Given this list of marker genes UBA1, MYSM1, SLC19A1, SLC30A7, DDX41, here is a description of the gene set: Dysplasia in the erythroid lineage, which presents with a variety of morphological changes in the bone marrow, including nuclear budding or irregular nuclear contour in erythroblasts. Erythroid dysplasia Human Gene Set: HP_ERYTHROID_DYSPLASIA studied in species Homo sapiens